Given this list of marker genes KNSTRN, HLA-C, MSMO1, TTC7A, CACNA1G, TP63, HR, HLA-DQB1, HLA-B, ADAM17, FLI1, IRF2BP2, PIK3CD, PIGA, IGHG2, IGKC, CARD14, CTLA4, AP1S3, NFKB2 (nuclear factor kappa B subunit 2), GJB2, IL36RN, IL2RA, BCL11B, SLC29A3, GJB6, FOXP3, LIG4, EGFR, DSG1, HLA-DRB1 (major histocompatibility complex, class II, DR beta 1), PI4KA, GATA3, here is a description of the gene set: Human Gene Set: HP_PSORIASIFORM_DERMATITIS species: Homo sapiens Psoriasiform dermatitis A skin abnormality characterized by redness and irritation, with thick, red skin that displays flaky, silver-white patches (scales).